The following is a description of a gene set: Reactome Pathway: Defective translocation of RB1 mutants to the nucleus part of: Aberrant regulation of mitotic G1/S transition in cancer due to RB1 defects This pathway describes impaired nuclear localization of RB1 mutants that lack the nuclear localization signal (NLS). studied in species Homo sapiens, and this is the list of marker genes: RB1